Given this list of marker genes Vps4b (NCBI Gene Id 319619), Vps4a, Pdcd6ip, Chmp4c, Chmp4b, here is a description of the gene set: studied in species Mus musculus The chemical reactions and pathways resulting in the breakdown of a protein or peptide, via the multivesicular body (MVB) sorting pathway; proteins are sorted into MVBs, and delivered to a lysosome/vacuole for degradation. This process is independent of ubiquitination. Mouse Gene Set: GOBP_UBIQUITIN_INDEPENDENT_PROTEIN_CATABOLIC_PROCESS_VIA_THE_MULTIVESICULAR_BODY_SORTING_PATHWAY